Given this list of marker genes KCNK13, here is a description of the gene set: Reactome Pathway: Tandem pore domain halothane-inhibited K+ channel (THIK) species: Homo sapiens part of: Tandem pore domain potassium channels THIK channels are K+ leak channels that are not regulated by pH or temperature changes.